Given this list of marker genes DNAJC21, SART3, PRKAA1, ASAP2, SOX9 (NCBI Gene Id 6662), HERC5, here is a description of the gene set: studied in species Homo sapiens from publication Chen Y, Wang X (PMID 31504780) Genes predicted to be targets of miRBase v22 microRNA hsa-miR-101-2-5p in miRDB v6.0 with MirTarget v4 prediction scores > 80 (high confidence targets). Human Gene Set: MIR101_2_5P